The following is a description of a gene set: This event has been computationally inferred from an event that has been demonstrated in another species.<p>The inference is based on the homology mapping from PANTHER. Briefly, reactions for which all involved PhysicalEntities (in input, output and catalyst) have a mapped orthologue/paralogue (for complexes at least 75% of components must have a mapping) are inferred to the other species. Reactome Pathway: SRP-dependent cotranslational protein targeting to membrane part of: Translation electronically inferred by orthology from the curated human pathway species: Mus musculus, and this is the list of marker genes: Rps25, Rpl38, Srp9, Rps8, Rpl18, Rps5, Rpl9, Rpl13, Rpl37, Rps3a1, Rpl37rt, Rpl29, Rps17, Rps2, Rps19, Rpl36al, Rps13, Rpl15 (NCBI Gene Id 66480), Rps4x, Rpl18a, Rpl26 (NCBI Gene Id 19941), Rps9, Rpl4, Rpl3, Rps20, Rps26, Rpl39l, Rpl39, Rpl3l, Rpl19, Rps15, Fau, Rpl27, Rpl12, Rpl6, Rps6, Rps27l, Srp54a, Rps10, Rpl37a, Rpl24, Rpl23a, Rps18, Rps24, Rpl14, Rps23, Rpl36a, Rps28, Rpl27a, Rpl7, Rps7, Rplp2 (NCBI Gene Id 67186), Ubb, Rpl11, Rps11, Rps12